Given this list of marker genes Fignl1, Dmc1, Firrm, here is a description of the gene set: part of: Cell Cycle; Reproduction electronically inferred by orthology from the curated human pathway This event has been computationally inferred from an event that has been demonstrated in another species.<p>The inference is based on the homology mapping from PANTHER. Briefly, reactions for which all involved PhysicalEntities (in input, output and catalyst) have a mapped orthologue/paralogue (for complexes at least 75% of components must have a mapping) are inferred to the other species. studied in species Mus musculus Reactome Pathway: Meiosis